The following is a description of a gene set: Uplifted earlobe Human Gene Set: HP_UPLIFTED_EARLOBE studied in species Homo sapiens An abnormal orientation of the earlobes such that they point out- and upward. That is, the lateral surface of ear lobe faces superiorly., and this is the list of marker genes: BMP4, PIGL, SRRM2, WWOX, PIGB, SLC32A1, CDC42BPB, MED25, SIN3A, ZEB2, EHMT1, TBL1XR1, LAS1L, AHDC1, IL1RAPL1, ERI1, KMT2C, PIGA, TWIST1, GRIA3, HDAC8, SMARCD1, NR2F1, MAPRE2 (microtubule associated protein RP/EB family member 2), BUB1, PIGQ